Given this list of marker genes SLC25A5, SLC25A4, SLC25A31, SLC25A6, SLC35B1, here is a description of the gene set: species: Homo sapiens Catalysis of the reaction: ATP(out) + ADP(in) = ATP(in) + ADP(out). Human Gene Set: GOMF_ATP_ADP_ANTIPORTER_ACTIVITY